The following is a description of a gene set: species: Mus musculus Mouse Gene Set: GOBP_FORMATE_METABOLIC_PROCESS The chemical reactions and pathways involving formate, also known as methanoate, the anion HCOO- derived from methanoic (formic) acid., and this is the list of marker genes: Hal, Shmt2, Uroc1, Amdhd1, Ftcd, Mthfd2, Mthfd1l